The following is a description of a gene set: studied in species Homo sapiens The neurological system process in which a signal is transmitted through the nervous system by a combination of action potential propagation and synaptic transmission. Human Gene Set: GOBP_TRANSMISSION_OF_NERVE_IMPULSE, and this is the list of marker genes: GPR88, CLDN19, CACNG4, ANK3, NPR2, CACNG2, CHRM5, ITGA2, SCN2A, GSG1L, CHRNA1, ATP1A2, KCNK2, AVP, JAM3, SCN11A, SCN4B (NCBI Gene Id 6330), SCN9A, CACNG7, KCNK4, KCNMB3, MTOR, RGS21, KCND2, PLEC, FMR1, SCN1B, S1PR1, KCNMB2, GPER1, DRD1, COL6A1, GHRL, DMRT3, SPTBN4, NRCAM, MTNR1B, GJD2, BBS10, GHSR, FKBP1B, HCN1, CACNA1I, CACNG5, MYH14, HCRT, KCNQ3, CNTNAP1, TRPA1, CACNG8, AVPR1A, OTOA, NTRK2, CARTPT, GRIK2, CHRNB4, CACNG3, MAG, KCNJ8, GRIA1, PAFAH1B1, GBA1, TNR, KCNA1, EFR3B, CACNB4, DRD5, GLRA1, CLCN1, CNTNAP2, P2RX1, GPRIN3, FGF12, PENK, ASIC5, SCN1A, KCNA2, SOD1, NTRK3, TYMP, KCNMB4